Given this list of marker genes GRIP2, SCRIB, RAB11A, CNIH3, GIT1, C1QL2, NETO1, OGT, RAPSN (NCBI Gene Id 85713), VPS35, NETO2 (NCBI Gene Id 81831), ADAM10, IQSEC2, ERBB4, DLG4, SACM1L, MAP2K1, GPHN, GRIN2A, GHSR (growth hormone secretagogue receptor), CACNG2, TMEM108, EPB41L3, CACNG7, DAG1, ERBB2, CACNG3, DLG1, LHFPL4, RAB8A (NCBI Gene Id 4218), LRRC7, ZDHHC15, OLFM1, GRIPAP1 (NCBI Gene Id 84538), TRAF6, NPTX1, C1QL3, KIF2C, GRIN2C, HRAS, LGI1, ARHGAP44, VPS26B, CLSTN1, NSG1, GRIP1, GPSM2, GABARAP, GPC4, RAP1A, STX3, CPLX1, ZDHHC2, VWC2, VAMP4, CACNA2D2, GPC6, here is a description of the gene set: studied in species Homo sapiens Human Gene Set: GOBP_PROTEIN_LOCALIZATION_TO_POSTSYNAPSE Any process in which a protein is transported to, and/or maintained at the postsynapse, the part of a synapse that is part of the post-synaptic cell.